Given this list of marker genes IER2, SERTAD1, ZDHHC9, JUNB, CXCL14, LOXL1, TNFSF13B, CNTFR, SCARA5, SLC20A1, C3, AKAP12, ACKR3, HAS2 (hyaluronan synthase 2), APOL1, LGALS3BP, SFRP2, H19, MRC2, SLPI, PIM1, PGM3, FGL2, MARCHF3, VEGFA, CADM3, FCGRT, CXCL12, CTSH, CST3, CTSK, IFITM1, VAT1, SRPX, NFKBIZ, ARF4, LSP1, CYBRD1, JUND (JunD proto-oncogene, AP-1 transcription factor subunit), NCOA7, SKIL, GPRC5A, IGF1, AKR1C2, SLC19A2, PTPRS, CCDC80, TIMP1, RCN3, CCL2, HSPH1, CLDN11, CD55, C1QTNF3 (NCBI Gene Id 81699), HAS1, PDLIM4, OAF, MEG3, OMD, CFH, CPE, SCPEP1, PTHLH, ALDH1A1, LDHA, GSTM5, CSF1, PAMR1, COL6A2 (collagen type VI alpha 2 chain), LAMB2, LMNA (NCBI Gene Id 7816), UCHL1, MMP2, BTG2, GSN, LGALS3, COL6A3, LXN, CTSF, FAIM2, CLEC2B, SH3BP5, PRRX1, COL1A2, BICC1, PLTP, LRP1, SLC16A7, FBLN2, MYC, GPNMB, ADH1B, PODN, FOS, SPSB1, PCOLCE2, ABCA8, FBN1, CTSL, XBP1, TNFRSF12A, CPVL, EMP1, MPZL1, DPYSL3, COL6A1, EGR1, BZW1, ESYT2, ABHD14A, GAS7, PID1, NPR1, GABARAPL1, CSRNP1, ANXA2, RDH10, FTL, HSPB8, TPST1, CD34, THBS2, IGSF10, AKR1C3, THY1, SSR3, PROS1, PDGFRL, SFRP1, DAB2, OSR2, SEMA3B, OSR1, FBLN1, SPTBN1, TCN2, ALDH1A3, APOD, ABCA9, IL32, NRP1, PTGIS, DPT, ZC3H12A, AKR1C1, LEPR, ITM2A, ERRFI1, CFD, LIMA1, TMEM176A, RTN4 (reticulon 4), YBX3, PDPN, PLBD1, CCN1, ABL2, CRABP2, RSPO3, C1R, PLAU, STEAP1, MGST1, PRCP, MEDAG, PLAUR, LOX, MFAP5, LRRN4CL, COLEC12, PCOLCE, FGF7, NEGR1, STEAP2, ABCA10, HSD3B7, COL3A1, SMS, ISLR, KLF4, UAP1, ACVRL1, SLIT2, SEMA3C, OLFML3, LRRC17, COL1A1, NFE2L2, IGFBP4, TGFBR2, REXO2, CD74, ATP1A1, PER2, NT5E, IL33, MT1G, MCL1, MAFF, TIMP2, NNMT, CD248, ANXA1, S100A10, PLK3, TSHZ2, JUN, UGDH, ABCA6, NR4A1, ZNF385A, PXDC1, DCN (NCBI Gene Id 1634), ZFP36, ABI3BP, ZFP36L2, C1S, S100A13, SERPINF1, TSC22D2, ADM, S100A6, CD44, FOSL1, CCN5, DNAJB1, IL1R1, PHGDH, PLAT, FGFR1, ACKR4, NUCB2, PPP1R15A, PTX3, FSTL1, F3, LINC01133, DCLK1, EFEMP1 (NCBI Gene Id 399564), BAG3, MYOC, CPXM2 (NCBI Gene Id 119587), SFRP4, MGP, AHR, IFI16, TIPARP, ABLIM1, MATN2, GAS1, B4GALT1, C16orf89, OGN, LTBP4, DHRS3, MOXD1, CYP1B1, FBLN5, CLMP, SVEP1, CHRDL1, ABL1, TNFAIP2, ZC3HAV1, S1PR2, SOCS3, NTM, LUM, HTRA3, PLA2G2A, AOX1, BDH2, DUSP1, LAMP2, RARRES1, GATA6, PDGFRA, FIBIN, ADD3, TUBB6, KLF2, FOSB, TSKU, ANK2, PI16, NOVA1 (NCBI Gene Id 4857), IGFBP6, RGMA, GFPT2, CYP27A1, C7, CLEC3B, S100A4, TMEM176B, MYDGF (NCBI Gene Id 80302), RGS10, here is a description of the gene set: from publication Travaglini KJ, Nabhan AN, Penland L, Sinha R, Gillich A, Sit RV, Chang S, Conley SD, Mori Y, Seita J, Berry GJ, Shrager JB, Metzger RJ, Kuo CS, Neff N, Weissman IL, Quake SR, Krasnow MA (PMID 33208946) Human Gene Set: TRAVAGLINI_LUNG_ADVENTITIAL_FIBROBLAST_CELL studied in species Homo sapiens